The following is a description of a gene set: Genes up-regulated in macrophages (12h): IFNG, TNF and rosiglitazone versus rosiglitazone and IL4. Human Gene Set: GSE16385_IFNG_TNF_VS_IL4_STIM_MACROPHAGE_ROSIGLITAZONE_TREATED_UP from publication Szanto A, Balint BL, Nagy ZS, Barta E, Dezso B, Pap A, Szeles L, Poliska S, Oros M, Evans RM, Barak Y, Schwabe J, Nagy L (PMID 21093321) Human CD14 positive monocytes were purified from healthy volunteers’ blood and cultured in vitro for 4, 12, 24, 72 hours. While culturing, macrophages were activated alternatively with interleukin-4 (IL-4 100 ng/ml) or classically with interferon-gamma (IFNg 100 ng/ml)+tumor necrosis factor (TNF 50 ng/ml) or left without activation. Simultaneously, macrophages were also treated with vehicle (DMSO:ethanol) or 1mM synthetic PPARg agonist, Rosiglitazone. We used Affymetrix microarrays (U133Plus 2.0) to analyze activation and PPARg-induced gene expression changes. species: Homo sapiens, and this is the list of marker genes: NAIF1, PDCD1, MACROH2A1, RNF145, RPRD1A, SUSD6, ZC3H4, EEF2K, ZNF17, CDK5R2, BTG3, RFPL1S, TMED8, FBXO30, CD53, CNOT6L, ZNF311, GZMB, IGHD, ABCA8 (ATP binding cassette subfamily A member 8), FAM167A, TAF12, ARHGAP10, ERP29, SUMO2, ARG1, POU2AF3, FOXN3, LZTFL1, KCNMB4, DUSP16, SMIM3, KRT15, DRAM2, AKIRIN1, DERL3, APP, EPSTI1, YPEL3, PEAK1, SH2D2A, KCNK10, CSPG4, SFTA2, ZNF527, TTLL2, SACS, CCSAP, B3GNT8 (UDP-GlcNAc:betaGal beta-1,3-N-acetylglucosaminyltransferase 8), SH3PXD2A, FRMD7, IFNB1, KIF14, CLEC2D, IFI16 (interferon gamma inducible protein 16), FN3K, PELI1, DHRS3, SH2B3, SNAI2, SLC26A4-AS1, PKIB, ADIG, ZNF630, CEP170, B3GALNT2, TGM6, TOMM20, AMZ2, CXCL8 (C-X-C motif chemokine ligand 8), SSBP3, PTBP3, MCUB (mitochondrial calcium uniporter dominant negative subunit beta), ENSG00000291065, SLC26A4, GSTM1, EML1, TRBC1, KRTAP4-3, AQP11, AIPL1, CRPPA-AS1, AK3, VDAC3, ZNF667-AS1, FAM83H (family with sequence similarity 83 member H), AZIN2, VDR (NCBI Gene Id 7421), TAB1, NIPSNAP3A, SKP2, C1orf94, ALDOC, FBXO27, SAMSN1, SNX18, AGO1, FBXO41 (NCBI Gene Id 150727), AUH, LINC00862, CCDC92, HSF2, CAMK2A, CSRP2, PLEKHH2 (NCBI Gene Id 130271), TRAV12-2, PCCA, IRF2BPL, PGAM2, TRDV2, PTGER2, EAF1, UNC79, PCP4, ARPC2, LILRB3, ZNF566, MACROD2-AS1, FGD4, BRPF3, FLRT2, EVA1B, MGC16275, CACNA1H, RAD51AP1, KLHL30-AS1, CAPN5, ABLIM3, RILP, KRT81, CYB5R2, DAAM1, POM121, GRIN2C, TEX35, CAGE1, ZNF519, GSTT1, MRAP, KPNA6, HBEGF, FCGR1BP, CCNB2, USP32, HIC1, STAP1, ENSG00000254531, GAB2, CLIC3, LEMD1-AS1 (NCBI Gene Id 284576), MIPEPP3, CIB2, SHCBP1L, RASSF9, FEZ1, TBC1D5 (NCBI Gene Id 9779), HOXA1, ACP6, CLCA1, TGFBR1, CREM, CCDC40, ARG2, SAT1, POC1B, ITPKB, MIR9-2HG, ARIH1, CD79A, PPP2R2B, SCARB2, VPREB3, ZNF563, MYL2, ENDOD1, ITGA4, IRF2BP2, KRT6A, PIK3C2B, ZNF90 (zinc finger protein 90), TMEM54, LINC01561, LINC02893 (NCBI Gene Id 440173), S100A7A, ZNF606, GRAMD1B, BTF3, ABCA9, FATE1, MYADM, FAR2P1, PPP1R15B, STX1B